The following is a description of a gene set: from publication Doronin K, Flatt JW, Di Paolo NC, Khare R, Kalyuzhniy O, Acchione M, Sumida JP, Ohto U, Shimizu T, Akashi-Takamura S, Miyake K, MacDonald JW, Bammler TK, Beyer RP, Farin FM, Stewart PL, Shayakhmetov DM (PMID 23019612) studied in species Homo sapiens Genes up-regulated in Lung dendritic cell from untreated IL-1R mice versus Lung dendritic cell from Ad5 T424A hexon inf IL-1R mice. Human Gene Set: GSE36078_UNTREATED_VS_AD5_T425A_HEXON_INF_IL1R_KO_MOUSE_LUNG_DC_UP Discrimination between self vs. non-self and adequate response to infection and tissue damage are fundamental functions of the immune system. The rapid and global spread of known and emerging viruses is a testament that the timely detection of viral pathogens that reproduce within host cells, presents a formidable challenge to the immune system. To gain access to a proper reproductive niche, many pathogens travel via the host vasculature and therefore become exposed to humoral factors of the innate immune system. Although a cascade of coagulation factors plays a fundamental role in host defense for “living fossils” such as horseshoe crabs (Xiphosurida spp), the role of the coagulation system in activation of innate responses to pathogens in higher organisms remains unclear. When human type C adenovirus (HAdv) enters the circulation, 240 copies of coagulation factor X (FX) bind to the virus particle with picomolar affinity. Here, using molecular dynamics flexible fitting (MDFF) and high resolution cryo-electron microscopy (cryo-EM), we defined the interface between the HAdv5 hexon protein and FX at pseudo-atomic level. Based on this structural data, we introduced a single amino acid substitution, T424A, in the hexon that completely abrogated FX interaction with the virus. In vivo genome-wide transcriptional profiling revealed that FX-binding-ablated virus failed to activate a distinct network of the early response genes, whose expression depends on transcription factor NFKB1. Deconvolution of the signaling network responsible for early gene activation showed that the FX-HAdv complex triggers MyD88/TRIF/TRAF6 signaling upon activation of toll-like receptor 4 (TLR4) that serves as a principal sensor of FX-virus complex in vivo. Our study implicates host factor “decoration” of the virus as a mechanism to trigger innate immune sensor that respond to a misplacement of coagulation FX from the blood into intracellular macrophage compartments upon virus entry into the cell. Our results further the mounting evidence of evolutionary conservation between the coagulation system and innate immunity., and this is the list of marker genes: GASK1B, ZNF341, GNAT2, GRK5, CYGB, NPDC1, RBM7, ACADM, MEAK7, DMRTA2, HTR2B, CLCN4, LRRC26, PRRG2, CHCHD2, PEX2, CCNJL, TWNK, DRAXIN, PPCS, ANG, ANK3, C1orf185, HABP4, SPINT2, LMOD1, WNT9B, PDILT, GCSH, PLA2G2E, TOMM7, SGMS1, LRFN1, LPCAT1, PROX2, PHOSPHO2, CD300LF, RANBP6, GNAL, APOC2, LYSMD2, TNP2, MICALL1, LIN7C, DERA, PLEKHH1, EVA1C, CXCL17, ACTR3B, CHSY3, ASB8, RGS10, GKN1, TBC1D5, CPLX1, GJB3, N4BP2L1, TNNI3K (NCBI Gene Id 51086), ACP6, YPEL2, SNRPA, NLRP14, TMEM236, HCRTR1, EFCAB3, TSLP, EGR2 (NCBI Gene Id 1959), OPHN1, TEX13A, C16orf89, CES4A, SSBP1, TMEM268, NTPCR, BMPR2, COL16A1, CHGB, DNAH17, THOC1, IL20RA, HACD1, APEX1, WDR48, KCNJ12, TFF1, ODR4, FEZF2, WDR11, LYZL6, LRRC45, SPG11 (SPG11 vesicle trafficking associated, spatacsin), HOXD12, CALR, NMNAT1, PWP1, IL17RD, SAA2, CINP, LAMA5, KCNA1, CMTM2, NPR2, CORO6, OCSTAMP, NOL11, ELANE, PROB1, KREMEN1, PLA2G12B, AMPD1, CASP8AP2, SEL1L3, BCORL1, SPPL2B, ENTPD3, PADI4, AKAP12 (NCBI Gene Id 9614), GSC, MRPL32, IL12B, MCM6, AICDA, NPRL3, CLDN19, MADCAM1, CCNJ, ZNF475, TSPYL1, TJP2, C14orf93, SRSF12, SPA17, CSRP3, IL36B, AKTIP, GPR158, FGF4, CFAP119, CBY3, SYN1, NLGN2, LYAR (Ly1 antibody reactive), ENDOD1, SNRPD1, CREG1, ANKRD29, SLC12A2, FBXO17, PCNX4, HAND1 (heart and neural crest derivatives expressed 1), GJD4, BBS2, IFI30, SLITRK5, DZIP1, NEPRO, TSACC, SPATA6L, SLC25A40, DIDO1, TIPRL, MINAR1, BLVRB, CILP, ARTN, GAA, TOX2, ZFAND1, MFAP2, CD34, CHRNG, TSPAN11, SNAP47, TRPM6, RAB11FIP2, SSTR1, FILIP1, CBLC, KRT24, GIPC3, COBL, DGAT2, CEP290, IL17D, RAB26 (NCBI Gene Id 25837), RXRA, GPR179, LTO1, SLC25A24, GCM2, LYG1, SPSB3, CDC42BPA, PLXNA1, SLC16A2, VPS54, TESMIN, ZIC3, DOK4